The following is a description of a gene set: Mouse Gene Set: GOBP_NEGATIVE_REGULATION_OF_HEMATOPOIETIC_STEM_CELL_DIFFERENTIATION Any process that stops, prevents or reduces the frequency, rate or extent of hematopoietic stem cell differentiation. studied in species Mus musculus, and this is the list of marker genes: Nfe2l2, Tmsb4x, N4bp2l2, Tcf15, Hspa9, Zfp36